Given this list of marker genes Tbl1x, Prrg1, Gm14760, Gm8722, Srsf8, Gm8806, Gm5940, Obp1b, Gm14744, Gm6954, Obp1a (NCBI Gene Id 18249), Gm8761, Gm14747, Gm6952, Gm14743, Gm4773, 4930480E11Rik, Actr3-ps, Gm16458, Tmem47, Gm5938, Gm14750, Gm14754, Gm14745, Gm22686, Gm8770, Gm5939, Cfap47, Gm14752, Gm5937, Gm8754, Mageb16, Gm14768 (NCBI Gene Id 100502701), Prkx, Rps24-ps3, Cldn34-ps, Gm8749, Pbsn, Gm8757, Gm14746, Gm4772, 5430402E10Rik, Fam47c, here is a description of the gene set: studied in species Mus musculus Mouse Gene Set: chrXB